The following is a description of a gene set: Human Gene Set: OUELLET_OVARIAN_CANCER_INVASIVE_VS_LMP_DN studied in species Homo sapiens from publication Ouellet V, Provencher DM, Maugard CM, Le Page C, Ren F, Lussier C, Novak J, Ge B, Hudson TJ, Tonin PN, Mes-Masson AM (PMID 15940270) Genes down-regulated in epithelial ovarian cancer (EOC) biopsies: invasive (TOV) vs low malignant potential (LMP) tumors. Tumors of low malignant potential (LMP) represent 20% of epithelial ovarian cancers (EOCs) and are associated with a better prognosis than the invasive tumors (TOV). Defining the relationship between LMPs and TOVs remains an important goal towards understanding the molecular pathways that contribute to prognosis, as well as providing molecular markers, for these EOCs. To this end, DNA microarray analyses were performed either in a primary culture or a tumor tissue model system and selected candidate genes showing a distinctive expression profile between LMPs and TOVs were identified using a class prediction approach based on three statistical methods of analysis. Both model systems appear relevant as candidate genes identified by either model allowed the proper reclassification of samples as either LMPs or TOVs. Selected candidate genes (CAS, CCNE1, LGALS8, ITGbeta3, ATP1B1, FLIP, KRT7 and KRT19) were validated by real-time quantitative PCR analysis and show differential expression between LMPs and TOVs. Immunohistochemistry analyses showed that the two tumor classes were distinguishable by their expression of CAS, TNFR1A, FLIP, CKS1 and CCNE1. These results define signature patterns for gene expression of LMPs and TOVs and identify gene candidates that warrant further study to deepen our understanding of the biology of EOC., and this is the list of marker genes: CIRBP, CFH, SMAD3, GNA11, RBP1, LGALS8, STX5, RPS29, GAMT, ITGB3, SHROOM2, KHSRP